Given this list of marker genes SHLD3, SHLD1, KLHL15, RIF1, RECQL5, POLQ, RADX, CGAS (NCBI Gene Id 115004), SHLD2, CSNK2A1, KAT5, FBH1, RMI2, UBQLN4, HELB, KMT5A, C1QBP, MAD2L2, FANCB, SMCHD1, SENP3 (NCBI Gene Id 26168), MAGEF1, ABL1, TP53BP1, PLK1, PARPBP, here is a description of the gene set: species: Homo sapiens Any process that stops, prevents, or reduces the frequency, rate or extent of double-strand break repair via homologous recombination. Human Gene Set: GOBP_NEGATIVE_REGULATION_OF_DOUBLE_STRAND_BREAK_REPAIR_VIA_HOMOLOGOUS_RECOMBINATION